The following is a description of a gene set: studied in species Homo sapiens Catalysis of the reaction: L-lysyl- + NAD+ = H+ + N(6)-(ADP-D-ribosyl)-L-lysyl- + nicotinamide. Human Gene Set: GOMF_NADPLUS_PROTEIN_LYSINE_ADP_RIBOSYLTRANSFERASE_ACTIVITY, and this is the list of marker genes: PARP10, PARP16, PARP3, SIRT6, PARP11